Given this list of marker genes HOXA1, FAHD2B, NMD3, SOCS2, FGF9, here is a description of the gene set: from publication Chen Y, Wang X (PMID 31504780) Genes predicted to be targets of miRBase v22 microRNA hsa-miR-3683 in miRDB v6.0 with MirTarget v4 prediction scores > 80 (high confidence targets). studied in species Homo sapiens Human Gene Set: MIR3683